Given this list of marker genes SFI1, LCK, PPP2R2D, SNHG32, PITPNC1, IFI44L, RXRB (retinoid X receptor beta), TAPBP, SERF2, PRKRIP1, TRAPPC6A, KIF17, ZNF45, ADA2, PHKA2, CLEC2B, CLUAP1, STK17A, PTPRCAP, TMEM254, PSME1, PDCD4 (NCBI Gene Id 27250), MAD1L1, PLCL2, TGFBI, VPS52, PIGC, YPEL5, FCMR, CMC4, GVINP1, MAN1B1, PRMT2, IFI6, PDK1, HEBP1, IPCEF1, PRKCZ, HIVEP2, GARRE1, UBL3, ZHX2, HLA-G (NCBI Gene Id 3135), RNF130, ZNF222, NFKB2, LEF1, PARP3, TRAC, GALNS, RRAS, RNF114, FAM171A1, C2orf42, IFIT3, PDE8A, ICAM2, MCM3AP-AS1, KLF9, IFITM2, ITGAM, EPHA1, VPS51, CTSO, PARP6, PDCD4-AS1, CROCCP2, TRANK1, ARID5B, ZC3H12A, COLQ, OLR1, FYB1, SURF1, CYTH1, ST14, R3HDM2, NME3, MAGED2, ZMYND11, MICA, MSC, ATP6AP1, RPS10P5, PEPD, EPHX2, RAB11FIP2, GP5, IL4R, IRF7 (NCBI Gene Id 3665), RPL28, ITGAX, KLF13, ACAP1, LY96, TNFSF15, TAGLN3, OAS3, MX2, CAPRIN2 (caprin family member 2), RABGAP1, REPIN1, CCDC92, ZNF148, SRSF5, DAZAP2, PPARD, H2AC6 (H2A clustered histone 6), PEX5, NAIP, TSC22D1, RNH1, IGLV1-44, NPC2, SMAGP, PLEKHB1, HERC5, SLC25A28, LAX1, KIAA0513, ENGASE, ATP6V1G1, RHOH (NCBI Gene Id 399), VPS8, GLS2, MOAP1, COQ8A, RABGAP1L, CKAP4, TTC3, CYBA, KAT8, MAL, SPOCK2, MPPE1, GBP2, ZNF419, MYOF, VPS28, HERC1, ZNF571, ZNF331, ZNF211 (NCBI Gene Id 90234), PILRB, KLF6, EDAR, EZH1, TRIM22, NAT9, SEC31B, IFI44, SPSB3, PGRMC2, TGIF1, ZNF137P, PIM2, MATK, PHF11, PCSK5, TREX1, LY9, TRIM44, NMT2, ANK3, LRP10, POLM, MAST3, ZNF395, PGS1, IL17RA, USP11 (ubiquitin specific peptidase 11), RPS5, OFD1, EIF3G, HLA-J, SPINT2, ZNF510, FBXL15, MAN2B2 (mannosidase alpha class 2B member 2), BBS9, CD247, ABLIM1, SLC35D2, CHKB, PLAC8, CRELD1, TRBC1, PNN, TIAM1, LILRB1 (leukocyte immunoglobulin like receptor B1), PDE6B, ABCA7, INPP5A, H1-10, RUNX1, IL1RN, PDGFC, PAN2 (NCBI Gene Id 9924), IL16 (interleukin 16), here is a description of the gene set: CD25+ regulatory T cells develop in the thymus (nTregs), but may also be generated in the periphery upon stimulation of naive CD4 T cells under appropriate conditions (iTregs). The mechanisms that regulate the generation of peripheral iTregs are largely unknown. We used microarrays to gain insights into the molecular program of extrathymic Treg development. studied in species Homo sapiens from publication Prots I, Skapenko A, Lipsky PE, Schulze-Koops H (PMID 21347372) Genes down-regulated in comparison of untreated CD25+ T effector cells at day 5 versus untreated CD25- T cells at day 5. Human Gene Set: GSE24634_TEFF_VS_TCONV_DAY5_IN_CULTURE_DN